Given this list of marker genes Rgs1, Hspa1b, Rnf19a, Dusp1, Fosb, Hspa1a, here is a description of the gene set: species: Mus musculus Mouse Gene Set: CUI_MIGDC_41BBL_RESPONSE_DN Genes negatively differentially expressed in cell type: MigDC (migratory dendritic cell) upon treatment with cytokine: 4-1BBL in mouse lymph nodes in vivo. Cytokines mediate cell-cell communication in the immune system and represent important therapeutic targets. A myriad of studies have highlighted their central role in immune function, yet we lack a global view of the cellular responses of each immune cell type to each cytokine. To address this gap, the authors created the Immune Dictionary, a compendium of single-cell transcriptomic profiles of more than 17 immune cell types in response to each of 86 cytokines (>1,400 cytokine-cell type combinations) in mouse lymph nodes in vivo. A cytokine-centric view of the dictionary revealed that most cytokines induce highly cell-type-specific responses. For example, the inflammatory cytokine interleukin-1β induces distinct gene programmes in almost every cell type. A cell-type-centric view of the dictionary identified more than 66 cytokine-driven cellular polarization states across immune cell types, including previously uncharacterized states such as an interleukin-18-induced polyfunctional natural killer cell state. from publication Cui A, Huang T, Li S, Ma A, Pérez JL, Sander C, Keskin DB, Wu CJ, Fraenkel E, Hacohen N (PMID 38057668)